Given this list of marker genes ASNS, CSDE1, SLC11A1, SERPINE1, GSTM5, FAM114A1 (family with sequence similarity 114 member A1), CCT3, AGRN, ADAMTS4, CBR3, CXCL6, HSPB2, FAM53C, FHIP1B, SLC39A4, PENK, VMP1, TRIM21, ABCC3, TANK, ARHGAP21, CHM, TOR1AIP2, TJP1, LZTFL1, PROCR, SLC6A13, DNMT3L, NLE1, H6PD, SLC13A3 (solute carrier family 13 member 3), BCL2L13, CD82, IRGM, TMEFF1, ACP3, CAV1, IKBKE, CX3CR1, ZNF146, IL12A, PTK2B, CH25H, COL5A1 (NCBI Gene Id 1289), TAP1, STAP1, MTHFD2, SLFN13, DTX2, CAMSAP1, SLAMF9, GSTA3, BATF, CRBN, TRMT112, NUPR1, MDFIC, HSPA1B, CYP1B1, RIDA, FPR1, TMED4, CD200, IL12B (NCBI Gene Id 7907), LAD1, OASL, AMPD3, SLAMF7, BLNK, MSANTD3 (Myb/SANT DNA binding domain containing 3), NPY, RHOQ, BIRC3, RNF135, KCTD1, PSD3, USP18, MMP2, ZNF281, ME1, CCL5, VEGFC, ACSL5, BLTP3A, RAPGEF1, CCND2, CYB5A, HACE1, RBM28, SUSD2, RAD17, ANTXR1, SLCO3A1, LRRK2, ENPP4, DGAT2 (NCBI Gene Id 84649), HCLS1, GOLGA7, CLK1, CD72, LYST, PANX1, VNN2, ENPP2, PC, ANKRD24, ARHGEF3, SLC25A37, RAB10, GSTM1, SH3BP5, PON3, IFT22, SLPI, MARCO, HSPH1 (heat shock protein family H (Hsp110) member 1), DNAJC1, MAML1, CRTC2, NOS2, SLC28A2, MTHFR (NCBI Gene Id 4524), CDKN2B, SEC14L1, ABCA1, ORM1, SLA, MYLIP, SLC15A3, LAMP2, TRIP13, PLA1A, FYB1, PLPP1, TMEM119, RNF19B, LYSMD3, LOX, C18orf32, AKR1B15, SYNE1, MTF2, FCGR3A, FSTL1, GHITM, RGS1, PKP2, BRD2, AOAH, TNIP1, GBP6, DUSP16, SLC1A2, TMEM165, DNAJB6, SEC22B, PIM2, ELL2, DGKA, CHPT1, EBI3, GBP2, BCKDHB, IGFBP4, PARP14, MARCHF5, ADGRE1, IGF2BP2, SERINC1, SNX10, HLA-B, GADD45B, IKBKB, NT5C3A, PDGFRB, CP, PKP4, REPS1, LLGL1, PLA2G4A, MS4A7, ACP5, PTGR1, JAK2, TBCEL, SOS2, ITGA5, HLA-E, GLIPR1 (NCBI Gene Id 11010), GCLM, SLC48A1, RDH11, LMO4 (LIM domain only 4), DENND5A, SCHIP1, GBP4, PPFIBP2, FAM20B, POU2F2, SACM1L (NCBI Gene Id 22908), here is a description of the gene set: from publication Amit I, Garber M, Chevrier N, Leite AP, Donner Y, Eisenhaure T, Guttman M, Grenier JK, Li W, Zuk O, Schubert LA, Birditt B, Shay T, Goren A, Zhang X, Smith Z, Deering R, McDonald RC, Cabili M, Bernstein BE, Rinn JL, Meissner A, Root DE, Hacohen N, Regev A (PMID 19729616) studied in species Homo sapiens mouse primary BMDCs were stimulated with tlr ligands and gene expression changes were profiled on Affymetrix arrays Human Gene Set: GSE17721_0.5H_VS_24H_CPG_BMDC_DN Genes down-regulated in comparison of dendritic cells (DC) stimulated with CpG DNA (TLR9 agonist) at 0.5 h versus those stimulated with CpG DNA (TLR9 agonist) at 24 h.